The following is a description of a gene set: A form of sensorineural hearing impairment that affects primarily the higher frequencies. High-frequency sensorineural hearing impairment studied in species Homo sapiens Human Gene Set: HP_HIGH_FREQUENCY_SENSORINEURAL_HEARING_IMPAIRMENT, and this is the list of marker genes: ASAH1, CEP250, ZMPSTE24, LMNA (lamin A/C), FGF3, FKBP14